Given this list of marker genes CHST15, GAL3ST4, SULT1C3, HS3ST5, ENPP1, SULT2A1, GAL3ST3, CHST12, UST, SULT1A1, here is a description of the gene set: Human Gene Set: GOMF_3_PHOSPHOADENOSINE_5_PHOSPHOSULFATE_BINDING Binding to 3'-phosphoadenosine 5'-phosphosulfate (PAPS), a naturally occurring mixed anhydride. It is an intermediate in the formation of a variety of sulfo compounds in biological systems. studied in species Homo sapiens